The following is a description of a gene set: Human Gene Set: GSE20500_CTRL_VS_RETINOIC_ACID_TREATED_CD4_TCELL_UP Genes up-regulated in CD4 T cells: control versus tretinoin. species: Homo sapiens This is to determine the T cell genes regulated by retinoic acid. from publication Kang SG, Park J, Cho JY, Ulrich B, Kim CH (PMID 20664575), and this is the list of marker genes: NLRX1, INPP5E, DCAF17, CNOT9, UNKL, BNIP3L, HINT1, TUBB, POU2F1, MRPL9, PRICKLE3, DNM1L, FEZ2, LMO4, MRPL28 (mitochondrial ribosomal protein L28), SCPEP1, CEP192, SORBS1, PCYOX1L, PSMB1, POP1, SNRPD3, NAT9, PGAP2, TP53, MTERF3, KIF2C, SLC38A10, HS6ST1 (heparan sulfate 6-O-sulfotransferase 1), LDHB, RAN, NARS1, CEP76, GIGYF2, CNOT8, NSDHL, BBS4, NDUFAB1, PEX14 (NCBI Gene Id 5195), TUBG1, DDX46, ACTL6A, ZBTB18, TESMIN, MIS18A, FHL1, DNPEP, RFK, PSMB2, SRPK2, CD244, MLYCD, PPCS, NDUFC2, APLP1, ZNF415, RPL34, PTPN18, SLBP, ABRAXAS2, ABCF3, LSM4, GSTA4, SLC25A6, CDC23, YLPM1, AP2S1, EIPR1, PWP1, SLC13A3, NDUFA8, VPS26A, NAA16, SYNCRIP, EYA4, LAS1L, ADAM10, FBXL5, SLC35A1, PRKDC, TMEM109, FAM162A, DAP3, KDELR2, MLC1, GNPDA1, IFNAR1, MANSC1, B4GALT6, DDX49, COA7, EFNA3, UBE2L3, SHMT1, ST3GAL4, SUPT20H, DOLPP1, TIMM17A, TMEM187, CHST2, ATP5ME, FZD3, NDUFB11, DCUN1D4 (defective in cullin neddylation 1 domain containing 4), CAD, ATP5F1D, METTL18, NECAP1 (NECAP endocytosis associated 1), ZFTA, CHFR (checkpoint with forkhead and ring finger domains, NCBI Gene Id 56732), PLEKHJ1, UNC119B, PTPRA, NOL7, VAV3 (vav guanine nucleotide exchange factor 3), CDKN2A-AS1, GINS2, MGST3, GPSM2, BCS1L, PEG3, PTGS1, UBE2E3, OCLN, PEX7, TNFAIP1, MED16, C11orf71, DHX32, BRCA2, ABHD17A, KEAP1, IDH2, RAB11A, HTRA2, RCAN1, DCP2, NGLY1, PPIE, PIGH, ZNF394, HARS2, HSD17B6, SNRPG, COQ4 (NCBI Gene Id 51117), HAGH, PINLYP, SPTSSA, ERP29, TRAPPC12, ASH2L, MTRR, CCT7, BARD1, OGDHL, BAG2, COQ8A, YIPF1, LMNB1, DNAJA3, NENF, ZSCAN32, LSM7, MEAK7, MRTFB, FBXO46, OARD1, PLSCR4, SPI1, CYP2E1, RAB5IF, PEX1, BMAL1, TTF2, HLA-DPA1, HTATSF1, COPS7B, TIPIN, SET, ANKRD17, CCNE2, C3AR1, PEX6, ZNF74, FN3KRP, MPST, E2F2, ARFIP2, HNRNPF, PRDX3 (NCBI Gene Id 29017), CEP68, ZHX3, CD99, PRKCH, HIKESHI, PDCL, LRRC20, NFKBIE, HIRA (NCBI Gene Id 7290), NUP62